Given this list of marker genes MKI67, LMNB1, GLIS2, SLC1A5, GPD1L, POU2AF3, TMEM51, CENPF, CENPE, HDAC2, SKA1, ABCC1, YBX3, MAD2L1, CDC6, RACGAP1, PELI1, SASS6, SEL1L3, AURKA, TRIP13, DEPDC1, TUBA4A, PIGAP1, MECOM, CEP55, TAP1, SPHK1, E2F8, SLC7A7, PTP4A3, JPT1, DEPDC1B, NDC80, S100P, LHFPL2, PM20D2, NT5DC2, ECT2, CMTM3, PRKCD, CYBA, IGF2BP3, PAG1, MARCKSL1, SYNJ2, ASPM, PAFAH1B3, RMI2, CCNB1, ZFAS1, CKAP4, LDLRAD3, DUSP9, CDC7, MTMR2, DSCC1, G6PD, MEP1A, DBN1, CTBP2, TNFRSF21, NCEH1, SALL4, TRNP1, PRC1 (NCBI Gene Id 9055), SLC16A3, TPX2, PKDCC, ANLN, MCUB, MAPK13, KIF23, DTL, MMD, KIF14 (kinesin family member 14), CCNA2, ATP1A1, ASRGL1, HJURP, TOP2A, TMED3, KIF20A, ZNF532, ZC2HC1A, MCM2, B4GALT5, CDK1, NUF2, FHOD3, SHCBP1, HMGB2, KIF4A, CCNB2, KIF2C, WASF1, PTTG1 (PTTG1 regulator of sister chromatid separation, securin), FUNDC1, BUB1B, ORC6, EZH2, BACE2, MMP9, SLAMF8, LRRC1, ETV4, VEGFB, TTK, SLC39A10, CCNE1 (cyclin E1), AURKB, ELF4, PDE9A, FLVCR1, UBE2C, DLGAP5, FBXO5, LAMB1, UGCG, FAM118A, CDC20, HELLS, PNMA1, TSC1, PLBD1, PKM, CKAP2L, NEK2, H4C3, SOX4, SALL2, ZWINT, KIF11, MMP12, PBK, BIRC5 (NCBI Gene Id 332), OIP5, P3H4, CD24, SOX9, FANCI, CHST11, BCAT1, RFC4, ELOVL7, ARID3A, PAPLN, KIF18B, TTF2, FMNL2, H19, FOXM1, HK2, CDCA7, WSB1, MARCHF3, CDKN3, CDCA5, SMC4, RAD51AP1, NCK2, SGO2, BARD1, CDCA7L, ARHGAP18, SELENOM, PLP2, MARCKS, GALNT7, B3GNT5, FDCSP, TMEM65, NUSAP1, FEN1, SLC38A1, PRR11, AFP, CENPK (centromere protein K), DDR1, here is a description of the gene set: Hepatocellular carcinomas represent the third leading cause of cancer-related deaths worldwide. The vast majority of cases arise in the context of chronic liver injury due to hepatitis B virus or hepatitis C virus infection. To identify genetic mechanisms of hepatocarcinogenesis, we characterized copy number alterations and gene expression profiles from the same set of tumors associated with hepatitis C virus. Most tumors harbored 1q gain, 8q gain, or 8p loss, with occasional alterations in 13 additional chromosome arms. In addition to amplifications at 11q13 in 6 of 103 tumors, 4 tumors harbored focal gains at 6p21 incorporating vascular endothelial growth factor A (VEGFA). Fluorescence in situ hybridization on an independent validation set of 210 tumors found 6p21 high-level gains in 14 tumors, as well as 2 tumors with 6p21 amplifications. Strikingly, this locus overlapped with copy gains in 4 of 371 lung adenocarcinomas. Overexpression of VEGFA via 6p21 gain in hepatocellular carcinomas suggested a novel, non-cell-autonomous mechanism of oncogene activation. Hierarchical clustering of gene expression among 91 of these tumors identified five classes, including CTNNB1, proliferation, IFN-related, a novel class defined by polysomy of chromosome 7, and an unannotated class. These class labels were further supported by molecular data; mutations in CTNNB1 were enriched in the CTNNB1 class, whereas insulin-like growth factor I receptor and RPS6 phosphorylation were enriched in the proliferation class. The enrichment of signaling pathway alterations in gene expression classes provides insights on hepatocellular carcinoma pathogenesis. Furthermore, the prevalence of VEGFA high-level gains in multiple tumor types suggests indications for clinical trials of antiangiogenic therapies. Human Gene Set: CHIANG_LIVER_CANCER_SUBCLASS_PROLIFERATION_UP from publication Chiang DY, Villanueva A, Hoshida Y, Peix J, Newell P, Minguez B, LeBlanc AC, Donovan DJ, Thung SN, Solé M, Tovar V, Alsinet C, Ramos AH, Barretina J, Roayaie S, Schwartz M, Waxman S, Bruix J, Mazzaferro V, Ligon AH, Najfeld V, Friedman SL, Sellers WR, Meyerson M, Llovet JM (PMID 18701503) studied in species Homo sapiens Top 200 marker genes up-regulated in the 'proliferation' subclass of hepatocellular carcinoma (HCC); characterized by increased proliferation, high levels of serum AFP, and chromosomal instability.